Given this list of marker genes Gtf3c1, Polr2l, Polr2f, Polr3c, Polr3h, Polr1c, Polr2e, Tbp, Bdp1 (NCBI Gene Id 544971), Gtf3c5, Polr3d, Crcp, Polr3g, Gtf3c6, Gtf3c3, Polr2k, Gtf3c2, Polr3e, here is a description of the gene set: electronically inferred by orthology from the curated human pathway Reactome Pathway: RNA Polymerase III Transcription Initiation From Type 2 Promoter studied in species Mus musculus part of: RNA Polymerase III Transcription Initiation This event has been computationally inferred from an event that has been demonstrated in another species.<p>The inference is based on the homology mapping from PANTHER. Briefly, reactions for which all involved PhysicalEntities (in input, output and catalyst) have a mapped orthologue/paralogue (for complexes at least 75% of components must have a mapping) are inferred to the other species.